The following is a description of a gene set: Mouse Gene Set: HOFFMANN_IMMATURE_TO_MATURE_B_LYMPHOCYTE_DN Genes down-regulated during differentiation of immature to mature B lymphocyte. studied in species Mus musculus from publication Hoffmann R, Seidl T, Neeb M, Rolink A, Melchers F (PMID 11779835) Gene expression profiles of five consecutive stages of mouse B cell development were generated with high-density oligonucleotide arrays from as few as 2 x 10(4) ex vivo isolated and flow-cytometrically purified cells. Between 2.8% and 6.8% of all genes change on differentiation from one cellular stage to the next by at least twofold. The entire pathway involves differential expression of 10.7% of all genes. Previously known expression patterns of genes (like surrogate light chain, RAG-1/2, MHC class II, mel-14 antigen) are confirmed. The gene expression patterns of the proliferating pre-BI and large pre-BII cells on the one hand, and the resting immature and mature B cells on the other hand, are most similar to each other. Small pre-BII cells display a pattern that is transitional between these two groups. Most of the genes expressed in early precursors are involved in general processes, like protein folding or cell cycle regulation, whereas more mature precursors express genes involved in more specific molecular programs (cell surface receptors, secreted factors, and adhesion molecules, among others). Between 19 and genes share a given expression pattern. Combining knowledge about gene function and expression pattern allows identification of novel candidate genes potentially involved in self-maintenance of pre-BI cells, allelic exclusion and pre-B cell receptor signaling in large pre BII cells, cell-cycle arrest of small pre-BII cells, propensity toward apoptosis or anergization in immature B cells, propensity toward cell division and activation in mature B cells, and stage-specific interactions with stromal cells in the bone marrow., and this is the list of marker genes: Mea1, Acy1, Myb, Wdr13, Grid2, Rbp4, Tax1bp3, Emid1, Pepd, Snrpc, Cd36, Vps45, Cdc45, ENSMUSG00000137801, Ccnd2, Foxn2, Myl4, Hbs1l, Gh, Akap17b, Abcd1, Ptgr1, Usf2, Cfp, Lhb, Lhx8, Pax2, Cox6a2, Atp5f1c, Ppp1r14b, Galk1, Tgfb1, Hes1, Bop1, Psme3, Stxbp2, Vpreb3, Dolpp1, Lipc, Atp1b1, Pld4, Marcks, Qki, Zfpm1, Uck2, Reln, Cd93, Hck, Nedd4